Given this list of marker genes ITPR1, RAPGEF4, PRKACB, SLC2A1, GNG7, GNGT1, GCG, GNAQ, SLC2A2, PLCB1, KCNB1, GLP1R, CD36, GNAI1, KCNJ11 (NCBI Gene Id 3767), CACNA1C, KCNC2, PRKAR2B, ADCY8, ACSL3, SNAP25 (NCBI Gene Id 6616), CACNA1A, PRKCA, GNB4, GNAS, PRKAR2A, GNA11, GNA14, IQGAP1, ADRA2C, CACNB2, INS, PRKAR1A, ADCY6, STXBP1, GNGT2, KCNG2, GNG8, ITPR3, CACNA2D2, ADCY5, GNG4 (NCBI Gene Id 2786), KCNS3 (NCBI Gene Id 3790), GNAI2, GNB1 (NCBI Gene Id 87729), GNB2, CACNA1E, RAP1A, AKAP5, ADRA2A, AHCYL1, GNB5, GNG5 (NCBI Gene Id 2787), ITPR2, PLCB3, GNA15 (G protein subunit alpha 15), GNG2, GNG13, MARCKS, ACSL4, VAMP2, GNG10 (NCBI Gene Id 2790), PRKAR1B, GNG12, FFAR1, STX1A, CACNA1D, CHRM3, ABCC8, GNB3, PRKACA, PLCB2, RAPGEF3 (NCBI Gene Id 27105), GNG11, CACNB3, PRKACG, SYT5, GNG3, here is a description of the gene set: Pancreatic beta cells integrate signals from several metabolites and hormones to control the secretion of insulin. In general, glucose triggers insulin secretion while other factors can amplify or inhibit the amount of insulin secreted in response to glucose. Factors which increase insulin secretion include the incretin hormones Glucose-dependent insulinotropic polypeptide (GIP and glucagon-like peptide-1 (GLP-1), acetylcholine, and fatty acids. Factors which inhibit insulin secretion include adrenaline and noradrenaline.<p>Increased blood glucose levels from dietary carbohydrate play a dominant role in insulin release from the beta cells of the pancreas. Glucose catabolism in the beta cell is the transducer that links increased glucose levels to insulin release. Glucose uptake and glycolysis generate cytosolic pyruvate; pyruvate is transported to mitochondria and converted both to oxaloacetate which increases levels of TCA cycle intermediates, and to acetyl-CoA which is oxidized to CO2 via the TCA cycle. The rates of ATP synthesis and transport to the cytosol increase, plasma membrane ATP-sensitive inward rectifying potassium channels (KATP channels) close, the membrane depolarizes, and voltage-gated calcium channels in the membrane open.<p>Elevated calcium concentrations near the plasma membrane cause insulin secretion in two phases: an initial high rate within minutes of glucose stimulation and a slow, sustained release lasting longer than 30 minutes. In the initial phase, 50-100 insulin granules already docked at the membrane are exocytosed. Exocytosis is rendered calcium-dependent by Synaptotagmin V/IX, a calcium-binding membrane protein located in the membrane of the docked granule, although the exact action of Synapototagmin in response to calcium is unknown. Calcium also causes a translocation of reserve granules within the cell towards the plasma membrane for release in the second, sustained phase of secretion. Human cells contain L-type (continually reopening), P/Q-type (long burst), R-type (long burst), and T-type (short burst) calcium channels and these partly account for differences between the two phases of secretion. Other factors that distinguish the two phases are not yet fully known. part of: Integration of energy metabolism Reactome Pathway: Regulation of insulin secretion species: Homo sapiens